The following is a description of a gene set: Any process that stops, prevents or reduces the frequency, rate or extent of mesenchymal cell apoptotic process. Mouse Gene Set: GOBP_NEGATIVE_REGULATION_OF_MESENCHYMAL_CELL_APOPTOTIC_PROCESS studied in species Mus musculus, and this is the list of marker genes: Shh, Pou3f4, Pax8, Hif1a, Dspp, Tbx1 (T-box 1), Hnf1b, Pax2 (NCBI Gene Id 207129), Gdf5, Wt1, Sox9, Bmp7